Given this list of marker genes MMP13, MMP1, BMP1, MMP14, MMP2, MMP9, ADAM23, ANPEP, MMP12, ADAM11, GGH, MMP10, MMP11, ADAM12, MMP23A, ACE, APC2, TRAF1 (TNF receptor associated factor 1), ADAM9, CPB2, MMP3, TRAF2, TIMP1, ADAM15, AEBP1, MMP7, KEL, ADAM10 (NCBI Gene Id 102), here is a description of the gene set: Human Gene Set: MODULE_210 Genes in the cancer module 210. species: Homo sapiens